Given this list of marker genes Ano6, Pcsk9, Ankfy1, Fcgr3, Rab27a (NCBI Gene Id 75673), Ptprc, Arrb2, Pard3, C2, Flot1, Dab2, Drd2 (NCBI Gene Id 13489), Kif3a, Anxa2, Il4, Apoa2, Cbl, Sele, Cd14, Ptk2, Cfp, Amph, Apoe, Fpr2, Fpr-rs4, Picalm, Sirpb1a, Ptprj, Fcnb (ficolin B, NCBI Gene Id 14134), Lrrk2, Ager, Pros1, Fcer1g, Hip1, Il15ra, Stap1, Wasl, Cd151, Clip3, C3, H1f1, Lbp, Sftpd, Itgb1 (integrin beta 1 (fibronectin receptor beta)), Nckap1l, Slc11a1, Trem2, Hnrnpk, Abr, Tub, Nsf, Abca7, Bin1, Grem1, Ldlrap1, Egf, Fcgr2b, Dnm1, Il15, Fmr1, Mbl2, F2rl1, Pick1, Abca13, App, Appl1, Dtnbp1, Plk2, Dnm1l, Rapgef1, Hamp2, Serpine1, Dll1, Colec11, Itga2, Dock2, Ap2a1, Myo18a, Fpr-rs6, Ccr7, Rap1a, Itsn1, Fcgr1, Ighg2b, Arrb1, Nlgn1, Trf, Tsg101, Fpr-rs3, Camk1d, Actn4, Wnt5a, Lrp1, Sod1 (NCBI Gene Id 319325), Lyar, Dnm2, Pld2, Arap1, Btk, Pparg, Cln3, Fpr-rs7, Cd36, Mff, Il2rg (interleukin 2 receptor, gamma chain), Vps28, Wnt3a, Il2rb, Cbll1, Tulp1, Cd209b, Cav1, Axl, Sh3gl1, Ahi1, Atad1, Plcg2, Cd63, Arf1, Smpd1, Rap1gap, Eef2k, Rab21, Clu, Caly, Hamp, Add1, Sfrp4, Ap2m1, Alms1, Mbl1, Nod2, Snap91, Vegfa, Pla2g5, Ccl21a, Aplnr, Rab31, Pycard, Ppt1, Ptpn5, Magi2, Snca, Tfr2, Ppp3ca (NCBI Gene Id 99901), Appl2, Gas6, Mertk, Ighm, Ckap5, Apln, Ccl2, Ighg1, Insr, Hip1r (huntingtin interacting protein 1 related), Cd47, Colec10, Gpc3, Dcx, Cyba, Clec7a, Sftpa1, Ahsg, Hspa8, Bcr, Ccl19, Apela, Mib1 (MIB E3 ubiquitin protein ligase 1), Bicd1, Sirpa (signal-regulatory protein alpha), Synj1, Cav3, Lrp2, Ptx3, Cdc42 (cell division cycle 42), B2m, Ntf3, Ap2b1, Myh9, Cd300lf (NCBI Gene Id 353028), Gata2, Dgkd, Tbc1d5, Nedd4l, Vtn, Angpt1, Sgip1, Ppp3cc, Bcl2l1, Lman2, Ifng, Hfe, Calr, Tor1a, Syk, Synj2bp, Apoa1, Mex3b, here is a description of the gene set: Any process that activates or increases the frequency, rate or extent of endocytosis. Mouse Gene Set: GOBP_POSITIVE_REGULATION_OF_ENDOCYTOSIS studied in species Mus musculus